Given this list of marker genes FCN1, MBL2, MASP1, COLEC10, MASP2, FCN3, COLEC11 (collectin subfamily member 11), FCN2, here is a description of the gene set: studied in species Homo sapiens Human Gene Set: REACTOME_LECTIN_PATHWAY_OF_COMPLEMENT_ACTIVATION Lectin pathway of complement activation